Given this list of marker genes Sox1, Gm11335, 0610009E02Rik, 5930409G06Rik, Gm12796, A830052D11Rik, Mkrn3, Nim1k, Gm29683, Cckbr, Mcf2, Gsx1, Gm6607, Ptprz1, Qrfprl, Hsd17b8, Gpr50, Gm28175, Gm18716, Ift27, Tm6sf2, Casp9, Kcnk10, Tarm1, here is a description of the gene set: Mouse Organogenesis Cell Atlas (MOCA) DE_gene_main_cluster.csv, fold.change>=1.5, qval<0.05, pval<0.05 species: Mus musculus Mouse Gene Set: DESCARTES_ORGANOGENESIS_OLIGODENDROCYTE_PROGENITORS from publication Cao J, Spielmann M, Qiu X, Huang X, Ibrahim DM, Hill AJ, Zhang F, Mundlos S, Christiansen L, Steemers FJ, Trapnell C, Shendure J (PMID 30787437)